Given this list of marker genes PAQR7, EI24, P2RX7, DUSP18, TAB1, GLE1, WDR5B, TUBA1A, KLHDC2, MVB12B, SYNJ2, THAP6, PLXDC2, UBR7, MKS1, ALG12 (NCBI Gene Id 79087), STEAP3, SUSD3, XXYLT1, QPCTL, TIAM1, GJA5, RARA, CEACAM1, PPP2R3A, AGAP2, INPP5K, FADD, CD93, MED15, MBD5 (NCBI Gene Id 55777), SMYD4, MAPDA, ARL11, SLC12A9, PDP1, MRPS27, AHSA1, GPR55 (G protein-coupled receptor 55), TMEM175 (NCBI Gene Id 84286), ING3, GNPNAT1, MSH3, FAM117A, CDKN2AIPNL, PTGS1, TXNDC5, GRAMD2B, OSBPL2, KBTBD3, FAM32A, ATP1A3, NDUFA1, OTUD3, TRAPPC1, CCR1, MLH1, GBA2, PLEKHO1, RAB23, RGS18, PAQR8, ARRB1 (arrestin beta 1), SELENOF, CD84, RNF115, CTDP1, NLK, ANKFY1, TPCN1, SOAT1 (NCBI Gene Id 6646), INTS3, CD52, DCAF17, DNASE1L1, SNX30, FBF1, PMS2, TNS4, CLINT1, MRPL27, GNE, GUK1, SEC11A, HEMK1, ANKRD26, CNNM2, CDK20, POLE3, NDST1, FAM53A, GCNT1, TMEM104, EXTL2, TEX261, PPIL1, KAT6B, DPYSL2, BAIAP2, XDH, CCDC32, FANCE, PFKFB2, SPECC1, LPAR6, C3AR1, RAB24, APBA1, TREM2, PRMT5, SRD5A3, XPOT, LMAN2, TBC1D14, SLC25A14, MSL3, GPR146, IL6R, SLC36A1, KSR1, PACC1, FLI1, LPAR5, H2BC21, GET1, CPPED1, ARHGAP45, TRIM65, MRPL36, ARL4C, RETREG2, CAMK2G, NT5C2, TMEM19, OPHN1, BTRC, MGAT1, FCGR3A, CORO1C, COQ10A, MTX2, SLC25A24, FBLIM1, SCAP, PDE4DIP, F2RL2, ZDHHC14, RASA3, MARCHF3 (NCBI Gene Id 153277), BLOC1S3, TAL1, LPCAT1, SLC29A3, MKNK2, NAA60, MAF1, LAMP1, SH2B1, CTDSP2, PIP4P2, AGL, TXNIP, RELT, LRRC8A (NCBI Gene Id 56262), CD300LB, RGS14, PIGN, TADA2A, SNX29, ALDH18A1, SH3GLB2, DHRS1, UQCC3, CLEC11A, MOB1A, FES, TMEM14C, C2CD2L, here is a description of the gene set: Human Gene Set: GSE27859_CD11C_INT_F480_HI_MACROPHAGE_VS_CD11C_ING_F480_INT_DC_UP Dendritic cells (DCs) and macrophages (MPs) are important for immunological homeostasis in the colon. We found that F4/80hi CX3CR1hi (CD11b+CD103-) cells account for 80% of mouse colonic lamina propria (cLP) MHC-IIhi cells. Both CD11c+ and CD11c- cells within this population were identified as MPs based on multiple criteria, including a MP transcriptome revealed by microarray analysis. These MPs constitutively released high levels of IL-10 at least partially in response to the microbiota via an MyD88-independent mechanism. In contrast, cells expressing low to intermediate levels of F4/80 and CX3CR1 were identified as DCs, based on phenotypic and functional analysis and comprise three separate CD11chi cell populations: CD103+CX3CR1-CD11b- DCs, CD103+CX3CR1-CD11b+ DCs and CD103-CX3CR1intCD11b+ DCs. In non-inflammatory conditions, Ly6Chi monocytes differentiated primarily into CD11c+, but not CD11c- MPs. In contrast, during colitis, Ly6Chi monocytes massively invaded the colon and differentiated into pro-inflammatory CD103-CX3CR1intCD11b+ DCs, which produced high levels of IL-12, IL-23, iNOS and TNF. These findings demonstrate the dual capacity of Ly6Chi blood monocytes to differentiate into either regulatory MPs or inflammatory DCs in the colon, and that the balance of these immunologically antagonistic cell types is dictated by microenvironmental conditions. Genes up-regulated in cells sorted as ITGAX int: EMR1 high macrophages versus EMR1 int dendritic cells. studied in species Homo sapiens from publication Rivollier A, He J, Kole A, Valatas V, Kelsall BL (PMID 22231304)